The following is a description of a gene set: species: Homo sapiens Dendritic cells (DC) serve a key function in host defense, linking innate detection of microbes to the activation of pathogen-specific adaptive immune responses. Whether there is cell-intrinsic recognition of HIV-1 by host innate pattern-recognition receptors and subsequent coupling to antiviral T cell responses is not yet known. DC are largely resistant to infection with HIV-1, but facilitate infection of co-cultured T-helper cells through a process of trans-enhancement. We show here that, when DC resistance to infection is circumvented, HIV-1 induces DC maturation, an antiviral type I interferon response and activation of T cells. This innate response is dependent on the interaction of newly-synthesized HIV-1 capsid (CA) with cellular cyclophilin A (CypA) and the subsequent activation of the transcription factor IRF3. Because the peptidyl-prolyl isomerase CypA also interacts with CA to promote HIV-1 infectivity, our results suggest that CA conformation has evolved under opposing selective pressures for infectivity versus furtiveness. Thus, a cell intrinsic sensor for HIV-1 exists in DC and mediates an antiviral immune response, but it is not typically engaged due to absence of DC infection. The virulence of HIV-1 may be related to evasion of this response, whose manipulation may be necessary to generate an effective HIV-1 vaccine. Human Gene Set: GSE22589_HEALTHY_VS_HIV_INFECTED_DC_DN Genes down-regulated in monocyte-derived dendritic cells: control versus HIV infection. from publication Manel N, Hogstad B, Wang Y, Levy DE, Unutmaz D, Littman DR (PMID 20829794), and this is the list of marker genes: FABP3, DUSP10 (dual specificity phosphatase 10), RAB19, FGF23, RNF31, NAA25, PTAFR, CAMK2D, TRIM13, ACSS1, IFT172, OAS1, DDHD1 (NCBI Gene Id 80821), C8A, ALDH1B1, RNF114, TCEANC2, RBM43 (RNA binding motif protein 43), SNX2, CARD6, ATP11B, SPAG6, GBP2, NPC2, MPST, ACP2, SH3TC1, NECTIN4, TLR1, DCBLD2, TSHZ3, C5AR1, THSD7A, SPATA18, GBP4, EPSTI1, STARD3, TLR7, TTLL7, PML (NCBI Gene Id 5371), FAR2, TGFB2, SLC49A4, PSMB9, IRF7, MX1, ANGPT1, PLCL2, VEZT, APTX, SAP30, OPTN, SLAMF8, ELMOD2 (ELMO domain containing 2), TLR3, RASA4, DTD1, STAU1, ALDH1L1, CASP7, SUSD6, IL1RAPL1, CLEC4E, BST2, PRR5L, TBC1D13, CCND1, S100B, STAT2, MCL1, CXCL11, USB1, DEDD, SLC30A6, SLC29A3, TCHHL1, CTNNAL1, ACP3, IRF1, TBRG1, PSME2, TMEM248, MOV10, CCDC122, RTP4, PTTG1, ALAS2, FAM53C, CD180, TNF, APLNR, TOR3A, DCAKD, LGALS3BP, C16orf78, MATN2 (matrilin 2), NUDT13, ST8SIA1, ADGRV1, TMCO3, ITIH3, LRRN4CL, TRAPPC14, GCNT7, PPP2R5A, CFAP54, GTF3C3, AKT3, POLR2C, FGD6, CCRL2, CTSW, TENT5A, PLOD2, TDRD7, C14orf93, CYBB, RBMS2 (RNA binding motif single stranded interacting protein 2), CH25H, GINM1, SETDB2, STXBP1, LHX5, PLK2, SLC9A3, TRAFD1, BAIAP2, HOXC5, ART5, TAP1, C19orf12, MX2, HRCT1 (histidine rich carboxyl terminus 1), ST14, LY6E, GBP6, SOCS1, SLC7A2, PNPT1, DCP2, GPSM2, STPG3, TAPBP, SLC28A2, DBNL, EIF4ENIF1 (eukaryotic translation initiation factor 4E nuclear import factor 1), TMEM198, FBH1, GBP7, PAPPA2, ATP6V1H, BLNK, NPNT, PARP14, SLFN5, UBA7, ENDOD1, LRRTM4, GJA3, IRF9, RUNX3, LRRK2, CD99, PSMB10 (proteasome 20S subunit beta 10), CGAS (NCBI Gene Id 115004), FAM241A, FRMD4A, HELZ2, CD70 (CD70 molecule), DDX60, SYT1, TBX6, LCP2, SECTM1, COX18, SOST, MAPKAPK2, NYX, NXPE3, EHD2, PPM1K, ADAMTS19, IFITM3 (NCBI Gene Id 10410), DOC2B, HTR7, CEP128 (NCBI Gene Id 283580), SLC25A22, JUNB, WDFY1, BRI3, GEM, PDGFRA, IL12RB2, NKG7, KCNQ2, HERC6, C11orf97, GYPC, TMED8 (transmembrane p24 trafficking protein family member 8), VAT1L